Given this list of marker genes A4GALT, TFCP2L1, NCAPG, GPR68, NEIL3, ADRA2A (adrenoceptor alpha 2A), UGT2B15, PPM1K, MCM7, ACOX2 (acyl-CoA oxidase 2), CHST8, PLAT, SERPINA1, MGAT3, MAT1A, SERPINA5, NAV2, NPY5R, NOD2, ATRNL1, TRPC6, KCNH1, H19, MGP, PLCL1, SPINK4, GAL, PRSS23, FHL1, GRIK3, LRP8, CA8, SOX3, GJB3, C1QTNF6, CTSD, TH, EXO1, CTPS1, PDLIM3, KLK11, GATA4, TMEM229B, THSD4 (thrombospondin type 1 domain containing 4), CYP26B1, MCM10, DSCC1, CHAC1, CD44, CCN5, BFSP2, NXPH3, RRM2, MPPED2, C5AR2, ARTN, here is a description of the gene set: from publication Li Z, Li T, Yates ME, Wu Y, Ferber A, Chen L, Brown DD, Carroll JS, Sikora MJ, Tseng GC, Oesterreich S, Lee AV (PMID 37272757) Human Gene Set: LI_ESTROGENE_LATE_E2_RESPONSE_UP High confident estrogen up-regulated genes in early treatment duration (≥ 24 hours) in breast cancer cells merged from 44 NGS datasets-based comparisons (10% topmost up-regulated genes and consistent in at least 50% comparisons). As one of the most successful cancer therapeutic targets, estrogen receptor-alpha (ER/ESR1) has been extensively studied over the past few decades. Sequencing technological advances have enabled genome-wide analysis of ER action. However, comparison of individual studies is limited by different experimental designs, and few meta-analyses are available. Here, by ingesting large amount of E2-related transcriptomic data sets in breast cancer cell lines, we identified gene expression changes across 66 RNA-seq and 80 microarray experiments based upon the E2-induced fold change in gene expression. Among the 146 merged transcriptomic datasets, 27 different time points were annotated spanning from 5 minutes to 600 hours of estrogen stimulation. We separated all the comparisons into three signatures of duration: EstroGene_Early (≤6 hours, n = 58), EstroGene_Mid (6-24 hours, n = 44) and EstroGene_Late (≥ 24 hours, n = 44). Upregulated and downregulated genes present in the top 10th percentile of regulated genes in each individual study, and consistently present across at least 50% of studies at each time period, were extracted from each signature (early, mid, and late) and intersected accordingly. We identified 165, 59 and genes representing early, mid, and late estrogen response signatures, respectively. species: Homo sapiens